Given this list of marker genes EIF3A, COPS7B, STK17A, MAN1A1, USP49, MTMR10, ANKRD20A1, IP6K2, CAMK2B, FMC1-LUC7L2, ANO8, EDNRA, ANKRD20A4P, CLINT1, FAM135A, NF1, UBR3, PHTF2, SERP1, SLC6A15, GNAL, BRCA2, DACH1, EGR2, ELOVL3, EIF1AX, MARCHF6 (NCBI Gene Id 10299), FAM169A, CNTN4, ALOX12B, NUS1, GCNT1, IQCB1, FCGR2B, EMSY, ADD3, FER1L5, TRAM2, ZBTB46 (zinc finger and BTB domain containing 46), SLC7A14 (NCBI Gene Id 57709), CALB1, CEBPG, PSMD8, RSF1, RRH, PDHA1, DCUN1D1, NUP93, NKG7, RIMS2, PPM1L, PARP9, C4orf33, FCHO2, TXLNB, SARAF, ZDHHC20, TRIM23, LMBRD2, PDE6C, ZNF273, TUBE1, GRIK1, GRIA3, SLC12A2 (NCBI Gene Id 6558), SOD2, AASS, TMED7, CPXM2, VMA21, ZNF230, LRRC58, ARID1A, ZNF660, GYPA, AGL, PDS5B, LIN7A, SNRNP27, GPSM2, OSBPL11, LAMTOR3, BUB1, NAGA, RBMS2, FLRT3, TIMMDC1, TF, MED13, FLT1, DSE, ZNF532, BIRC6, ASB5, ZNF721, PBX1, CCER1, KANSL1, TIAM1 (TIAM Rac1 associated GEF 1), RAI14, LRP2BP (NCBI Gene Id 55805), NNT, PLCH1, SPRY2, NFIA, IQCJ-SCHIP1, RBMX, ZNF680, CYP4B1, CC2D2B, LUC7L2, DOCK7, UGT2B28, CSRNP3, TTC39B, GRK3, CDK13, BAZ1A, ANKRD20A3P, ANKRD20A2P, HRH4, PURB, RCOR2, SLC16A7, SUZ12, TOP2B, SPOCK3, MTTP, DNAAF5, DAPP1, here is a description of the gene set: from publication Chen Y, Wang X (PMID 31504780) Genes predicted to be targets of miRBase v22 microRNA hsa-miR-653-5p in miRDB v6.0 with MirTarget v4 prediction scores > 80 (high confidence targets). Human Gene Set: MIR653_5P species: Homo sapiens